The following is a description of a gene set: Catalysis of the reaction: GDP-beta-L-fucose + beta-D-galactosyl-(1,4)-N-acetyl-D-glucosaminyl-R = GDP + 1,4-beta-D-galactosyl-(1,4)--N-acetyl-D-glucosaminyl-R. Human Gene Set: GOMF_4_GALACTOSYL_N_ACETYLGLUCOSAMINIDE_3_ALPHA_L_FUCOSYLTRANSFERASE_ACTIVITY species: Homo sapiens, and this is the list of marker genes: FUT6, FUT7, FUT3 (NCBI Gene Id 2525), FUT5, FUT4, FUT9